Given this list of marker genes EEIG1, RPTOR, IL20, NOTCH2, TNFSF11, POU4F2, TM4SF19, SLC9B2, POU4F1, TMEM64, PPARGC1B, IL12B, CCR1, TYROBP, KLF10, IFNG, CREB1, TNFRSF11A, TREM2, GPR68, IL17A, IL23A, IL23R, NEDD9, OCSTAMP, PPP3CA, CSF1, TNF, TRAF6, FOS, here is a description of the gene set: Human Gene Set: GOBP_POSITIVE_REGULATION_OF_OSTEOCLAST_DIFFERENTIATION studied in species Homo sapiens Any process that activates or increases the frequency, rate or extent of osteoclast differentiation.